Given this list of marker genes Prnp, Prkci, Cdk5, Ldlrap1, Stac2, Atp2b4, Zdhhc5, Actb, Ngdn, Ephb2, Pdpk1, Sfn, Ramp3, Vamp8, Ppp1r9b, Tmem108, Cnst, Lypd1, Myo5a, Rab11a, Camk2d, Rhog, Csnk2a1, Rab38, Ogt, Adam10, Lrp1, Zdhhc7, Lgals3, Pik3r2, Gpc6, Kif5b (kinesin family member 5B), Myo5b, Tnik, Ezr, Efcab7, Numb, Ap2m1, Pls1, Epm2a (epilepsy, progressive myoclonic epilepsy, type 2 gene alpha), Wnt3a (NCBI Gene Id 22416), Map2k1, Pgrmc1, Dlg1, Plk1, Rapgef4, Picalm, Rab11fip2, Neto2, Gpc4, Stx7, Itga3, Ppfia1, Bcl2l1, Actr3, Gabarap, Epha2, Stx4a, Kcnj11, Numa1, Camk2b, Sirt6 (sirtuin 6), Epb41l1, Iqsec2, Acsl3, Cplx1, Pkdcc, Stx3, Vps26b, Ins2, Sapcd2, Abi3, Akt1, Vil1, Gpsm2, Eif4g1, Pias1, Nrxn1, Trem2, Grip1, Dpp6 (NCBI Gene Id 51817), Pkp1, Hectd1, Atp2c1, Arf6, Epb41, Zdhhc2, Magi2, Abca2, Stac, Gsk3b, Traf6, Sorbs1, Stac3, Snca, Camk2g, Mmp14, Commd1, Rap1a, Kif2c, Vti1b, Epha3 (NCBI Gene Id 353311), Dab2, Dag1 (NCBI Gene Id 13138), Wnk4, Tmed2, Nhlrc1, Arhgef16, Clip3, Vps35, Csk, Hras, Epb41l2, Camk2a, Pik3r1, Cdh1, Rer1, Egfr, Arhgap44, Agr2 (anterior gradient 2), Lyplal1, Csrp3, Dpp10, Lrrc15, Ptpn9, Tnf, Cnpy4, Kalrn, Sptbn1, Rangrf, Lztfl1, Cltc (NCBI Gene Id 97762), Tmbim1, Akap5, Nkd2, Stx8, Cib1, Gper1, Ghsr, Wnk1, Rack1, Cacna2d2, Cln3, Mrap, Nbea, Sqstm1, Gnai1, Itgb1, Appl1, Rhoq, Vamp4, Cacng2, Ins1, Tgfb1, Vps4a, Pid1, Mrap2, Prkcz, Ar, Wnk3, Ppp2r5a, Misp, Gripap1, Lypla1, Tmem59, here is a description of the gene set: Mouse Gene Set: GOBP_REGULATION_OF_PROTEIN_LOCALIZATION_TO_CELL_PERIPHERY species: Mus musculus Any process that modulates the frequency, rate or extent of protein localization to cell periphery.